Given this list of marker genes ELAVL1, MAGI2, ZNF384, AAK1, MEGF11, CXCL10, EIF4ENIF1, ABHD17C, TCAF1, KIF13A, ARID4B, RBMS1, EFEMP1, FAXC, CPEB2, ABCC5, ARFGEF1, CCDC126, ATXN7L3, TMEM130, BCL6, GABPB1, PRR20E, THAP11, RBBP5, TMEM165, RXRG, KCNJ6, CNKSR2, ZIC2, VAV3, HPS1, CDH11 (cadherin 11), NET1 (neuroepithelial cell transforming 1), BACH2, HCN1, VEZF1, MCOLN3, CNTN1 (contactin 1), GSK3B (glycogen synthase kinase 3 beta), REV3L, RALYL, HS3ST1, PAPPA, RNF38 (NCBI Gene Id 64796), KAT6A (NCBI Gene Id 7994), NEK6, EBF3, KCND2, BBC3, CPEB3, SGK1, MEMO1, HAPLN1, SLC20A2, MBTD1, PCGF5, SDC3, SLITRK5, RORA, LARP4, DNMT3A, STARD4 (NCBI Gene Id 154899), SLC6A17, ATAD2B, VLDLR, MED13L, DACH1, CCNG2, SUSD6, TANC2 (tetratricopeptide repeat, ankyrin repeat and coiled-coil containing 2), HS6ST3, NFKBIA, ZEB1, TMTC1, RTL8A, UBE2G1, NID1, C15orf40, ITGA10, TAB2, KDM3A, POLH, DSCAML1, JMJD1C, ANP32B, ATL2, RAB5C, TDO2, LMX1A, ADGRG3, DAB2IP, M6PR, DPY19L4, CADM2, ALX1, NFIA, CXXC4, GGNBP2, ADGRL2, NR2F1, ZNF638, PPARGC1A, ZNF367, AKAP1, NECTIN3, NAMPT (NCBI Gene Id 10135), FZD4 (frizzled class receptor 4), FBXO34, PDSS2, KRTAP4-9, BAP1, BCL11B, DYRK4, BRD10, LETM2, DLC1, FAM43A, COLEC12, IQCK, TNFSF11, RFX3, ITGB1, PRIMA1, SLC35A3, KCNK1, GABRA5, BRD1, MAP4K3, HMGB2, HAT1, TMEM106B, AP3S1, ZFAND5, FLI1, CCSER1 (coiled-coil serine rich protein 1), CDH4, CTDSPL2, AFF4, MYT1L, FLT3LG, ZNF341, TSPAN3, HMGN1, TMSB4Y, BAZ1A, TRHDE, SNRPB2, XPO4, NAT8L, TBP, GNAL, FIRRM, NKX2-1, HID1, CDADC1, HSD11B1, FBXL3 (F-box and leucine rich repeat protein 3), MRFAP1, TGFBRAP1, RXRA, KPNA4, ANKS1A, VAV2, DCTN2, TOMM20, C16orf54, FBXO38, LRIG1, FOXJ3, TCF7L2, PPP1CC, RASL11B, SHISA6, WTAP, ARHGEF3, MBD5, ZNF143, SYNGAP1, RAI1, GNG5, KAT6B, CIBAR2, HECTD2, BAG3, C1QL1, LIAS, RMC1, UNK, SLC24A2, SF3B1, GDF6, SHOC2, ATP2A2, HIVEP1, USP42, ANTXR1, GRB10, KLF7, VANGL2, GDNF, BCL2, PLCB1, ROCK1, PRR20D, STXBP5L, WIPI2, OSBPL6, PRR20B, FUBP1, TMEM170B, LRP12, MYCBP2, RAB14, NECAB1, RASGRF1, TENM3, SP3, SLC35F3, MAP3K20, CUL1, RBM27, SNAP91, BCAS1, HOXA1, B3GNT9, QSER1 (glutamine and serine rich 1), LRRTM3, OSR2, PRR20C, ARL8A, CITED2, ARL8B, SLAIN2, PGAP1, SP1, PDE4D, ATP13A3, LIN28B, IL1RAP, AP4M1, ABTB2, ATP5MK, CDYL, SALL3, MXRA5 (NCBI Gene Id 91006), MEA1, RBMS3, NLK, SLITRK3, ADGRL3 (NCBI Gene Id 23284), SAT1, CRISPLD1, FMR1, USP6NL, MSH3, C1QBP (NCBI Gene Id 708), DCUN1D1, PRR20A, RAD21, RD3L, PGRMC2, MBNL2, PSMA5, ZNF90, SH2B3, PDGFRA, FLRT1, FLRT3, SMG1, KANSL1L, FAT1, CACNA1D, PAPSS2 (NCBI Gene Id 9060), PPP4R1, FEZF2, NCOA6, MYO1E, ARHGAP11A, ARHGAP44, IP6K1, TAOK1, LINGO1, RFX4, KDM2B, CD83, UCK2 (uridine-cytidine kinase 2), here is a description of the gene set: Human Gene Set: LET_7A_2_3P from publication Chen Y, Wang X (PMID 31504780) studied in species Homo sapiens Genes predicted to be targets of miRBase v22 microRNA hsa-let-7a-2-3p in miRDB v6.0 with MirTarget v4 prediction scores > 80 (high confidence targets).